Given this list of marker genes NUF2, TRIM37, LPIN3, GNG12, MIR3178, LINC02268, TSSK3, USP1, TTC5, NR1H3, NCOA3, PTK2B, PPP4R3B-DT, PTCD1, FRAT1, RTF2, RNH1, TIA1, LINC03044, RAD50 (RAD50 double strand break repair protein), PRKCD, LINC00265, SECTM1, PLA2G4B, ZSCAN25, PTP4A1, PRMT6, LGR4, SNHG17, WDR59, ROCK1P1, ATP2A2, PEX1, SLC6A6, LINC03052, TBC1D15, TMTC2, GRK6, BOLA1, ENSG00000237813, DPY19L3-DT, POLG-DT, FOXA3, SERTAD2, CD63, SLC25A5, HNRNPH1, RHOXF1P1, ZHX1, TIGD6, STRN, AJUBA, VDR, MRPS18C, PIAS3, CPSF4, RPL26L1, RPL26L1-AS1, PTGES2, PARP1, CCDC146, POLR1E (NCBI Gene Id 64425), HCG14, SSR4P1 (signal sequence receptor subunit 4 pseudogene 1), ANG, MT-RNR2, ZFAS1, EED, PEX13, RPS12, ENSG00000246308, KLF6, NFE2L2, DEPTOR-AS1, DEK, NSD1 (NCBI Gene Id 6797), SWT1, MAPK6, TDRKH-AS1, GATA6, SNX11, NSMAF, BTNL12P, MIR211, DSTN, ARFRP1, CNNM2, SC5D, VAPB, UQCC6, FAM124A, PPP4C, C17orf67, LINC02585, UBA6-DT, LINC01569, H2BC15, ZC3H10, KATNBL1, JUN, TMEM177, HSDL2-AS1 (NCBI Gene Id 100507604), HACL1, LINC03079, HEATR6, PPP1R13B (protein phosphatase 1 regulatory subunit 13B), RBM48, SELENOKP3 (NCBI Gene Id 100508868), ARHGEF9, DHX40, MAP3K9, AHCTF1, RIDA, SPHK2, MAGOHB, VAPA, MBNL1-AS1, MTF1, RPSAP31, WDR54, NIPA1, ESRP1, SLC25A30, RNFT1, GTF3C6, DEPDC4, ILK, GPR19 (G protein-coupled receptor 19), ISL2, HMGXB3, DYNLL1, TBC1D22A, SPEN-AS1, MT-ND6, TBC1D25, RIN1, C8G, TTC39C-AS1, PNPLA8, SFT2D3, TUBA4A, CCDC97, ERBIN-DT, RNF150, KCTD9, SCIN, MT-TM, ZNF536, LINC03086, VPS52, MT-CYB, CTTN, DPY19L3, RAD1, SMPDL3A, VPS37B, RRAGAP1-AS1, SLIRP, HGS, NECTIN4, MADD, GABPB1, SNRNP48, CIT, RNU6-450P, TIPIN, ERLIN2, SIL1, NOL8, CABP1, RNU6-8, BRWD1, MRFAP1, ZNF770, C17orf75, EHBP1L1, CLDN12 (NCBI Gene Id 9069), NOTCH2P1, POLR3B, NCK2 (NCK adaptor protein 2), MIR4448, FRG1DP, SEMA4C, C14orf28, VPS53, HMGB1 (NCBI Gene Id 3146), SNAI3-AS1, MLF1, CDON, CAT, THEM4, RNVU1-3, HOXA6, RABL3, FAM185BP, SLC7A5P2, CFAP418, GRHL2-DT, ZMYND8, PHOSPHO1, RBIS, IPPK, THOC7, SP1, SETD9, MT-TT (mitochondrially encoded tRNA-Thr (ACN)), SCGB2B3P, PIPOX, SEC16A (SEC16 homolog A, endoplasmic reticulum export factor), UBE2V2, MB21D2, SYMPK, LINC01237, B3GAT3, IFT25, NADK (NCBI Gene Id 65220), ICAM4-AS1, OS9, SPIRE2, GPRC5C, GLB1L2, RRN3 (NCBI Gene Id 92636), USP37, GNAQ, ACTMAP, C2orf49, PPP1R13B-DT, THAP5, ADGRF4, KDM3A, CA13, ALKBH1, RNVU1-15, MRPS2, SZRD1, DGKE, SECISBP2L, ZNF646, SEC11A, PRMT5, CCDC174, DECR2, TMEM30A, MFSD4B-DT, RANBP2, LMO7, H4C1, CYREN, CUL1, TIGD2, PNRC1-DT, ZDHHC6, DDHD1-DT, RPRD1B, LYRM2, GALNT16-AS1, NDUFV2-AS1, STAT4-AS1, PAFAH1B1, ULBP3 (UL16 binding protein 3), CD302, ZNF544, EVA1B, SNORA17B, TCP11L2, ZSCAN32, CRTC2, MIDEAS, HUNK, SLC25A19, TENT5A, SNX16, PGAM1, PRDM10, ATP6V0E2, YWHAG, DCUN1D4, TBX2-AS1, STAT6, PPP1R15B, PLEKHG2, AXIN2, TGFA, MRPL45P2, HEXA-AS1, CEP112, RGS20, PA2G4, TMEM167B, REL-DT, TTC41P, CREBRF, TMEM70, VTRNA1-3, SEPTIN1, PPP4R2, CELSR3, LINC00869, RMRP, G3BP1, ZGPAT (zinc finger CCCH-type and G-patch domain containing), NEDD1, PSMD6, CCDC107, RNF43, LDAH, CYP1B1, KLC3, C1QBP, JMJD6, SNHG10, INTS13, CEACAMP10, DCAF4, ZNF217, PSMB4, TUBE1, HMGCL, PCBP2, EFNA3, CDKN1A, PPP1R14B-AS1, EIF3B (NCBI Gene Id 8662), ZNF234, CCT4, TSPAN14-AS1, CAMSAP2, KCTD21-AS1 (KCTD21 antisense RNA 1), MLF1-DT, CTNNA1, AKNAD1, KCNK2, DDIAS, RPL22, TMEM9B-AS1, SNORA84, FAM229B, ZNFX1, HNRNPDL, SLC27A5, SNRNP25, EIF4G2, ATXN1, VANGL1, DDX39B-AS1, TBC1D13 (TBC1 domain family member 13), NRK, POP1, STAU2-AS1, TUBA1B-AS1, FKBP9, PCBP3, EXT1, HIKESHI, ARL16, KNL1, RNU7-27P (RNA, U7 small nuclear 27 pseudogene), IL6ST, AP3S2, BCORL1, EMD, C19orf53, SAMD4A, DCLRE1B, ZNF174, KIF23, ZNF331, CFAP251, RTBDN, RAB11A, TRUB2, SYBU-AS1, DNAJC2, TTC39A-AS1, SUPT5H, MAPKAPK5-AS1, POLD4, CAV2, UBR5-DT, TOP3B, SMARCC2 (SWI/SNF related, matrix associated, actin dependent regulator of chromatin subfamily c member 2), ZSCAN2, LINC02112, KAT14, EXTL3, VPS45, ZNF141, USPL1, CIPC, SORBS3, SLC29A2, MIR3155A, STMN3, HIGD1AP5, RBBP8, ZNF311 (NCBI Gene Id 282890), INPP5B-AS1, RARG, AMZ2, ZNF398, RIPK4 (receptor interacting serine/threonine kinase 4), PWWP2A (NCBI Gene Id 114825), ATXN7L3-AS1, RPS10, MAML3, CREBBP, NANS, ADGRB3, ENSG00000260830, COX16, AKR1E2, HSPD1, MT-TL1, JUN-DT, LINC01275, UGT1A6, IER2, RIC8A, CHN2, CYCS, AKAP10, GALNT10, ARHGAP5, RPAP3, LTA4H, ZHX1-C8orf76, SF3B2, CDK2AP2 (NCBI Gene Id 10263), ELMOD3, CCDC112, UBTF, MCM4, TDRKH, NADSYN1, RTEL1, AHRR, ZNF101, CPT1A, TPH2, NUP58, ADH5, MAGED1, TMEM14B, PRCP, NDUFC2 (NADH:ubiquinone oxidoreductase subunit C2), ZNF581, MAP2K7, MEAK7, PLEC, LINC02762, FAM227B, CIB2, ALCAM, RPRM, MOCS2, NCEH1, GHR, ADK, TSHR, PIERCE1, PDE11A, ING3, TBC1D3P1, DEPDC1B, KIF23-AS1, FHIP1A-DT, FRG1HP, EID2B, ID1, EEF1A1, RPS29P16, LINC01132, DTWD2, MIR9-2HG, RNVU1-2, PPOX, GLS, MAPK6-DT, ITPR1, ELOC, ERBIN, LINC02453, ZNF510, THOC2, BHLHE40, IL5, ZNF860, PSMB6, AGFG2, WDR36, NUDT16-DT, BUD31, GLCCI1, ENSG00000269091, PRANCR, PET117, DTNA, NR4A2, C2orf49-DT, SLFN5, SRSF1, ID3, ARAF, P2RY6, RPS10-NUDT3, MBLAC2, BCAS1, TBC1D9B, IBA57-DT, ENSG00000275765, S100PBP, UQCRB, TSPAN15, KIAA1958, SOCS3, NME1, RSBN1, CCDC88C, EIF4A1, MT-TA, CDHR18P, NDST1-AS1, RASSF1, PAXBP1, RERG, POLR3K, TUBB4B, VPS26C, NSUN4, NFYA, RNU6-2, SNRPA (small nuclear ribonucleoprotein polypeptide A), GPSM2, KDM5B, MT-ND1, COQ4, CNOT9, SAAL1, STC2, VMP1, NAMPT, NDUFA12, ILF2, CGRRF1, RNVU1-2A, CCDC59, HCCS, PDP1, ORC2, RNASE4, MT-TC, PPIL6, GPC4, TAF13, LIMA1, BMPR1A, PDE4DIPP6, MRRF, FOSL2-AS1, FAM216A, DCLRE1C, ZNF148, PROSER2, STAM2, SAMD12, BICRAL, KXD1, SAYSD1, RETSAT, MIR5093, ANAPC13, ACAN, TMEM144, CDC14B, HIPK1, MBTPS1, SNX14, TEDC1, LINC02934, PIK3R1 (NCBI Gene Id 5295), ZNF140, GABPB1-AS1, PEAK1, BCL2L12, RAD9A, LINC-PINT, PGRMC2, ACSF3, ATXN7, PTRH2 (peptidyl-tRNA hydrolase 2), RPS6KA5, TRIM7-AS2, FHIP1A, ARL4A, PRRT1B, CYP26A1, ZNF780A, FUBP1, CTNNA1-AS1, FGFR1OP2, RAP2C-AS1, RNFT2, NQO1-DT, SMARCD2, HSPA6, CEP83-DT, ENSG00000246090, COA6-AS1, WDR45B, CLK3, FAH, MINCR, NOB1, RN7SL446P, PABPN1, EBAG9, PKP4-AS1, EPHB1, ZNF48, FBL, CROCCP2, ENSG00000277301, TSPYL2, INTS2, XNDC1N (XRCC1 N-terminal domain containing 1, N-terminal like), ZNF774, PRTFDC1, TCF25, SUGCT, ABHD11, MOCS2-DT, RGS6, DDX43, ERCC6, ENPP3, CNBD2, CNOT2, SRCAP, DNAJB4, POLR3G, COX17, SLC38A1, COA6, AZIN1 (antizyme inhibitor 1), EPHA3, B4GAT1, TMEM266 (NCBI Gene Id 123591), ZNF275, MEIS2, CDYL, IFRD1, H3C12, RELA, GAD1, GOLGA4, TTLL4, GREB1 (growth regulating estrogen receptor binding 1), JARID2 (NCBI Gene Id 3720), ENSG00000267248, ZIC2, SV2C, MCL1, SALL4, THAP7, CAND1, TXNL1, FAAH, HARS2, SCNN1A, TCTA (NCBI Gene Id 6988), TM2D3, PSMD9, DGLUCY, RAB8A, SMPD4BP, ATXN2L, SIPA1L1, LINC01484, LPP (NCBI Gene Id 4026, LIM domain containing preferred translocation partner in lipoma), SNX12, TMEM123, KLF4, LRCH3, LINC00511, RNU6-9, BRK1, LINC02518 (NCBI Gene Id 105377957), SETMAR, GULP1, POLR1A, TBCA, LRIG2-DT, ACP2, ACBD5, RBM28, ADAP1, PPIA, TMEM18 (NCBI Gene Id 129787), CDK20, FTSJ1 (NCBI Gene Id 4408), RNF139, SLC9A6, GRPEL1, CNN2, LINC02598, BCL7A, ARRB1, FBXL12, TPRN, NUDCD1, NRP1 (neuropilin 1), ARRDC3, SNORD12C, C2orf42, TAF2, VPS51, ACTR3BP2, DYNC1I2, CEP63, GPN3, LRRC27, MAX, SCAND1, ENSG00000254337, LRFN2, OTUB1, BMP4, APBA2, TIMM8A, DHX9 (NCBI Gene Id 3450), HLA-A, NAA60, C5orf24, KANSL3, SLX9, COQ7, DHFRP2, LMAN1L, FASTKD2, DNAJB2, SUN1, TRAF3IP2-AS1 (NCBI Gene Id 650970), PUS10, ERP29, RSAD1, FRG1BP, RNU6-369P, NEURL2, PPP1R12B, SLC25A45, P4HB, GGH, TPM4, APBB3, USP32, TBX3, AGXT (NCBI Gene Id 51432), MLH1, FGF11, HSPE1-MOB4, POLG2, ATXN7L1, PRMT9, CUTA, APEH, POLR3E, HNRNPUL1, RPAP3-DT, ARID2, LINC00475, SMAP1, COPS4, CDC42EP3, SLC30A1, BRIP1, VTCN1, GLRX5, OVOL1, LRRC58, TRIB1, BLM, TMEM106B (NCBI Gene Id 54664), RBBP8NL, SPRY4-AS1, TBC1D19, FAM174B, REXO4, CDC20, STARD7, SFXN2, EML6, NES, MT-TY (NCBI Gene Id 4579), METTL23, RNU11, PHF3, LYSMD3, UBE2N, SMC2, INHA, MDH1B (malate dehydrogenase 1B), SPAG17, H2AX, H3C7, SLC44A1, ATXN7L3, RASSF1-AS1, SRBD1 (S1 RNA binding domain 1), ATF7IP, ASAP2, RPS6KB1, ZER1, CTB-30L5.1, ALKBH8, SIKE1, ZBTB14, SMIM6, GAS2L3, TGFB3, NOM1, PRMT5-DT, TTC9C, KIF3A (kinesin family member 3A), MAP3K9-DT, MRPS15, NISCH, CHRM1, LACTB (NCBI Gene Id 84943), ENSG00000260136, FOSL2, SMAP2, ZMIZ1, NONO, PLD1, HARS1, E2F7, PFAS, STAG3L5P, FOXN2, RNVU1-21, EPS8, METTL25, AP4E1, ACOX1, WDPCP, ASAH1-AS1, FAS, ENSG00000233017, KCNN4, PCNT, TSPEAR, NSMCE4A, PWP1, ELF2, RABGGTA (Rab geranylgeranyltransferase subunit alpha), SP2-AS1, MPIG6B, TUFT1, AKR1D1, PIK3R3 (NCBI Gene Id 8503), DNAJB5, LRRC37A6P, COQ7-DT, SNHG7, CIZ1, PSMC2, MYH9, MIR5087, TBC1D22A-DT, TMEM69, MIR4251, MYOF, ESYT1, PHACTR2, MYRFL, SLC35A4, MRPL44, B3GALNT1, WDR73, CMTM3, SYNPR-AS1, VIRMA-DT, RYBP, GPR137, C7orf25, NDUFC2-KCTD14, AKT1, MIR4521, ADARB1, SLC16A7, RBPJ, CYP1A1, TUBA1B, CHD1L, PABPC1, TMEM9B, CPLANE2, MARCHF6, IGF1R, CADPS, SAR1B, CD22, KIAA0895LP1, STX10, SPATA2, R3HDM2-DT, MT-TD, HDAC5, PEX26, CHSY1, LINC02569, FIS1, DHRS13, SPICE1, GIPC2, STAG2, PTGES2-AS1, VPS33A, MARCHF6-DT, HMGN4 (NCBI Gene Id 10473), DNM1, MYNN, FOXJ3, ANAPC2, MFSD4B, CENPP, MED16, GTF2H3, OXCT1, SLC30A6, YARS1, ZNRF1, ZNF181 (zinc finger protein 181), PARL, TMEM39A, CPEB4, METTL2A, TMEM30A-DT, PIR, ZCCHC7, MRPL53, TPRA1, AP5B1, LARP1, H3-3B, CRTC3-AS1, RPS18 (NCBI Gene Id 6222), CTNND2, UBE2F-SCLY, PDS5A, MT-ND2, NPRL2, EMSLR, MBNL1, CBLN3, SEPHS1, CFL1, MRPS18A, NCAPG2, ADIPOQ, TTLL9, FBXO27, TRMT10C, QSOX1, IL6R-AS1, PYCR3, TRIM41, MT-TE, GET4 (NCBI Gene Id 51608), SSBP2, HEG1, LHFPL6, TMED10, RNF7, ADCK5, LINC01547, ATP1B3, CSDE1, MFSD1, ZNF23, TRIM35, NUMA1, PTPRG-AS1, STIP1, GMCL1, MT-TI, KIFC2, HOXC8, IARS1, GCAWKR, CACYBP, MDH1, FGF9 (fibroblast growth factor 9), ZNF652-AS1, NRF1, SNORD101, OSBPL6, PAFAH2, CUL9, RPL18, MIR4734, ARRB2, BRIX1, GPANK1, ZNF519, SLC27A2, MIR193BHG, ZNF669, SCAP, MT-TN, CLNS1A, MIR4664, ALG8, HES1, OSBPL10, FAM185A, KNSTRN, CEP83, GTF2E1, SS18, LINC00240, ENSG00000224905, CA8, DYNC2I2, MAP1LC3B, GATA6-AS1, AP3M2, ZNF419, TPRG1-AS1 (NCBI Gene Id 100874043), RCC2, TLK2 (NCBI Gene Id 11011), RALGAPA2, RSU1, STK32C, NEAT1, RHOA (ras homolog family member A), SNX8, SLC1A5, CDCA7L, PLCB1, ERCC6L2-AS1, GANAB, LINC02846, RGS5, UBE2D3, PDAP1, PTMA, H3C11, UBE2S, LHX6, KPNB1, MIB2, FAM83H (family with sequence similarity 83 member H), RUNX1T1, ICAM5, BMP7, FYN, OARD1, POLR2L, ZNF687-AS1, FBXW5, AXDND1 (axonemal dynein light chain domain containing 1), LINC00963, IBA57, OXA1L, RPL22L1, SCARNA20, MAP1LC3BP1, EEF1D, DSTYK, CAPZA2, CDS1, EIF1, CHCHD7 (NCBI Gene Id 79145), ANKFY1, PPP4R3A, ARL3, BCAS4 (NCBI Gene Id 55653), HMG20A, RECQL5, HSPBP1, THAP12, NSG2, SMG1P3, VTI1A, GPALPP1, PSMG3-AS1, SPRED1, DYNLRB1, PPP4R3B, NUDT17, TMEM131, C16orf95-DT, ESCO1, CDYL-AS1, PPP1R11, DDX39B, SCARNA2, HSP90B1, ESPN, SMAD2, PTCD3, CA5BP1, CSNK2B, BMS1P2, ZNF260, RNVU1-6, MBLAC1, VLDLR, UBE2F, ZNF652, C1orf216, COP1-DT, HECTD1, RNVU1-30, RRP12, RBM17, RCOR1, PPP1R14B, ZNF750, LARP4B, ZNF280D, IDH3A, VPS13C-DT, SMPD2, RNF139-DT, EIF2B5, WDR26, MACROD2, MORF4L2, VTRNA1-2, BFSP1, TRIM33, OXA1L-DT, MIR378D2HG, DHX15, APMAP, TLCD1, SDCBP, PRELP, NME1-NME2, WDR33, FREM2, PPIH (NCBI Gene Id 10465), BMI1, SGO2, RBM18, DPP9, RABGAP1L, HBP1, ZNF668, SPG21, PHF12, NFE2L1-DT, SEC22B, PSMG3, CDC20-DT (CDC20 divergent transcript), DDHD1, DNAJB5-DT, IPO11, RPSA, ANKRD12, CIART, GVQW3, ADAMTS9, RRM2B, ENSG00000227355, PRKRIP1, RPS10P7, HCCS-DT, C21orf58, RNF121, RRP8, ZNF16, SPIN1, CTSA, MIR153-1, HELQ, SBNO1, STAT1, RPL30P11, EPM2AIP1, HEATR6-DT, ANKRD33BP1, LRIG2, JARID2-DT, ERCC6L2, ASAH1, CCNL1, STAG2-AS1, ERBB2, IRF3, RUFY1 (NCBI Gene Id 80230), WDR37, APPBP2, CEP15, LINC01962, VLDLR-AS1, GLUL, RGMB-AS1, TAS2R1, RNVU1-14, COMMD1, ABI1, AGAP1, TRIM9, RNF224 (ring finger protein 224), PRKAB2, ZFTRAF1, UFSP1, LINC01918, SOS1, IQANK1, ADGRE2, TRIP12, CTDP1, YWHAZ, NQO1, KCNIP2, TBX1, SPATS2L, SPRING1, ENSG00000293341, HEXA, XXYLT1, PNPO, KAT2B, KLF10, MSL2, MYBL1, PFN2, ZNF295-AS1, HMGN3P1, SLC2A4RG, DM1-AS, PPP1R21, DCAF11, HM13, TMEM248, BAMBI, INPP4B, FCHSD2, TFF1, TRGC1, MRPS23, RPS6KA2, GRHL2, SCYL2, JPX, USP38, THAP7-AS1, DTWD1, NFE2L1, DTX4, DKC1, SLC25A5-AS1, TMEM185A, PARD6B, PPP3R1, PANK1, ENSG00000257545, ANKRD9, NIPSNAP3A, STON1-GTF2A1L, RAD51C, GZF1, SEC63, ZNF687 (zinc finger protein 687), HIPK1-AS1, TBC1D3P1-DHX40P1, APRT, SUPT16H, MST1P2, PLAG1, SYNPR, CCDC88C-DT, LSM14B, AJUBA-DT, VEGFA, GTF2A1 (general transcription factor IIA subunit 1), LHX4, MIS18BP1, PSPC1, PNRC1, LARGE1, SLC3A2, IFFO2, ZKSCAN8, ENSG00000232995, LINC01719, IDS, ARRDC2, ZBTB12 (NCBI Gene Id 259267), TRMT1L, GRB2, POLG, EXD2, GCA, ZSCAN9, DENND2C, BTD (NCBI Gene Id 92108), DIMT1, SLC7A1, MAPKAPK5, TMEM259, FANCI, LAPTM4B, NUFIP1, CYB561D2, MZT2A, TMSB15B, SELENBP1, NAMPT-AS1, GOLGA1 (golgin A1), MED23, WBP1L, HS3ST3B1, EIF2B1, PLCG1, PPP1R21-DT, CRNDE, TGIF1, CDKN1B, TTI1, KSR2, ATG12, BATF, HSPE1, SGF29, EXOSC6, LINC01623, ENY2, TMEM14B-DT, FAXDC2, CHCT1, PCF11, RNU6-1, SUSD6, SLC9A8, ARHGEF1, UBR5, USP12, KHNYN, COP1, FAM83B, NEK8, SP3, TSPAN4, MT-TV, LDB1, RNA5S17, CISD2, RIPOR2, IRX5, REV3L, PARD3B, GTF2A1-AS1, ENSG00000235978, VIRMA, AK2, ING5, LRP12, AIFM1, NRAV, SYBU, FBXO31, DNASE1, MPLKIP, SNORD126 (NCBI Gene Id 100113391), B4GAT1-DT (NCBI Gene Id 102724064), NADK2, IDI1, SOX6, RAB6C-AS1, R3HDM2, ASCC2, AP3S1, ACTR2, SCAANT1, USP38-DT, POR, UBA6, APPBP2-DT, NME2 (NME/NM23 nucleoside diphosphate kinase 2), ATF3, SAC3D1, PLEKHO1, GRIA2, ZNF35, ZNF223, TMBIM1, SNUPN, RASA3, SLC2A11, ALKBH5, PPM1D, MILIP, NOD1, EGLN3, HPS3 (HPS3 biogenesis of lysosomal organelles complex 2 subunit 1), DDX3X (DEAD-box helicase 3 X-linked), BMF, TTLL12, BFSP2, ITFG2-AS1, PTGES3, NAAA, CDCA2, SRPK1, here is a description of the gene set: from publication Yevshin I, Sharipov R, Kolmykov S, Kondrakhin Y, Kolpakov F (PMID 30445619) Human Gene Set: AHRR_TARGET_GENES species: Homo sapiens